Given this list of marker genes Etf1, Gspt1, N6amt1, Apeh, Gspt2, Trmt112, here is a description of the gene set: species: Mus musculus Eukaryotic Translation Termination Mouse Gene Set: REACTOME_EUKARYOTIC_TRANSLATION_TERMINATION